Given this list of marker genes ELAPOR2, SLC37A3, ATXN1, GLIS3, BIRC6, HTR2A, MACROH2A1, ATP10B, TMEM135, CRBN, CYP1A1, SLITRK4, CPSF6, PID1, ROBO2, CCDC40, SRSF7, COX5A, CHRM2, ABRAXAS2 (abraxas 2, BRISC complex subunit), SLC2A13, ARMC8, APC, C9orf57, ELAVL3, ESRRG, IMMP2L, TFDP3, HSPH1, PHIP, POU2F1, UCHL5, POM121, GDF6, NF1, KCNK9, IL6R, RMI1 (RecQ mediated genome instability 1), CEP350, SUN1, RAB5A, TCF12, KIF15, PLPP3, SUMF1, RPS6KA5, SKI, ATP2B4, CDK7 (NCBI Gene Id 116024), UBN2, PTGR3, CACNA1C, SH3PXD2A, LRP6, TMEM106B, ZNF37A, C2orf68, SPRY3, TMED4, AGAP1, C2CD2, LPP, TAOK1, SLC4A8, RAB40B, ACSL4, FGFR1, UBA2, GABBR2, EID1, MLLT11, ELAVL4, CUL3, SUZ12, THRB, CXCL14, SLC28A3, SGIP1, PAQR9, NUDT5, MAP3K2, CTNNA3, ROR1, FRMD4A, NRBF2, NFIB, GAD1, ARFGEF1, COL5A1, PGGT1B, CRHBP, NCAPG2, SLC5A3, SNX13, KDM5A, ZBTB7C, COG6, ATP6V1C2, FSHB, EPC2, FEM1C, ITGA2, UEVLD, CCBE1, SLC17A8, TNFSF13, AIPL1, IRF2, TMEM123, OXTR, C1orf185, RAB22A, EXOC6B, SOX14, EVI5, LIG3, BCL2L2, OTUD7B, MLLT3, CDYL2, LYSET, ANKRD13A, PAIP2B, UGT2B28, ZFX, MAU2, B3GNT5, HAPSTR1, ZDHHC23, CLEC2B, BPNT2, ADRA1D, TNFAIP6, PHOX2B, UBA6, PPARG, WDR26, ATL2, RPL17-C18orf32, CREB5, HOXC6, VPS37B, NR2F1, USP31, TMEM183A, WAPL, HECA, CECR2, TMEM255A (transmembrane protein 255A), DLG1, ZBTB4, TMOD3 (NCBI Gene Id 29766), POTEC, PPM1L, DIXDC1, EDEM3, CENPA, CEP68, GPR26, CRAMP1, MMP16, KPNB1, ZNF189 (zinc finger protein 189), KXD1 (KxDL motif containing 1), STN1, WRN, ICE2, CELF2, NEXMIF, PLXDC2, B3GLCT (beta 3-glucosyltransferase), VAMP4, NLRP2B, ACTR2, YPEL2, MRPS17, ZEB2, PRUNE2, ELAVL2, ZBTB34, CLPX, TNPO1, SCAI, FAM13C, NEURL1B, FGFR2, FAM98B, PIP4K2B (NCBI Gene Id 8396), SHC1, ZNRF2, NAA40, STIMATE, AGPAT5, AP1S3, POU3F2, MTF1, MTCH2 (mitochondrial carrier 2), SMAD4 (NCBI Gene Id 4089), FAR2, RAB14, C18orf32, PCDH7, RHEX, RAD54L, GRIN2A, ITIH5, AK2, SPOP, NFIA, MARCHF3, ONECUT2, ATXN2, TNRC6B, DNAAF9, PLEKHM3, ZNF704 (NCBI Gene Id 84737), MBOAT2, MEIS2, NBR1, MAPRE2, CHD5, KLF7, JADE3, CRACD, TET2, MAP1B, CACNA1G, PLD5, RASL10A, GUCY1A2, M6PR, MCOLN1, CNOT6L, FBXL22, NTRK2, EIF2AK3, ARL1, COQ2, TMEM52B (transmembrane protein 52B), SLC44A5, PAQR3, PPP2R1B, PPARGC1A, FOXC1, GABRB1, TOX3, ZDHHC14, CCDC50, GID8, DPPA5, TRIM10, ZNF793, RNF169, STXBP5L, MYADML2, CALCRL (calcitonin receptor like receptor), BMP6, STRADB, SLC35B1, TNFAIP3, TENT5A, ANKRD44, GDF9 (growth differentiation factor 9), C14orf28, FRAS1, MTMR7, PIAS1, FBN2, ZNF131, EDRF1, SASS6, GPR37, ZMYM4, TMEM183BP, VSNL1, ARCN1, SGCD, BCL11A, DIPK2A, GTF3C3 (NCBI Gene Id 9330), ECE1, UGT2B4, MYCT1, SAMD5, CNKSR3, POLR3G, ZBTB20, SCUBE3, TLCD4, IGFBP5, ZKSCAN1, YPEL4, PRTG (protogenin), PTPN7, VGLL3, C9orf40, JARID2, MTCL1, PLXNA2, STIL, BNC2, UBE2Q1, ARHGEF2, PTPRT, here is a description of the gene set: studied in species Homo sapiens from publication Chen Y, Wang X (PMID 31504780) Human Gene Set: MIR4446_5P Genes predicted to be targets of miRBase v22 microRNA hsa-miR-4446-5p in miRDB v6.0 with MirTarget v4 prediction scores > 80 (high confidence targets).